The following is a description of a gene set: A delay in closure (ossification) of the anterior fontanelle, which generally undergoes closure around the 18th month of life. Human Gene Set: HP_DELAYED_CLOSURE_OF_THE_ANTERIOR_FONTANELLE Delayed closure of the anterior fontanelle species: Homo sapiens, and this is the list of marker genes: ATP7A, MED12, GRB10, PEX19, ANKRD11, HDAC4, CTSK, ATP6V1A, ATP6V1E1, IGF2, POLR3A, H19, RPS6KA3, ZFX, ZIC1, TOMM7, DSE, ANTXR1, FLNA, FAM111A, NLRP3, ATP6V0A2, TBCE, GH1, COL1A1, AMER1, PEX14, PEX2, ASPA, SEC23A, RUNX2, NCAPG2, SMC3, ADAMTS2, BANF1, MMP2